Given this list of marker genes ACBD5, ACBD7, PANK1, TAF1 (NCBI Gene Id 6872), PANK3, ACADVL, SCP2, DBI, GCDH, ACOT7, ECI2, ACBD3, NAA80, SOAT2, SOAT1, ACBD4, ACBD6, PNPLA3, here is a description of the gene set: Human Gene Set: GOMF_ACYL_COA_BINDING species: Homo sapiens Binding to an acyl-CoA, a thioester that results from the formal condensation of the thiol group of coenzyme A with the carboxy group of any carboxylic acid.